The following is a description of a gene set: Regulatory circuits of STAT3 signaling studied in species Homo sapiens Human Gene Set: WP_REGULATORY_CIRCUITS_OF_STAT3_SIGNALING, and this is the list of marker genes: STAT3, MAPK7, IL5RA, SOCS3, DUSP2, EGFR, IL15RA, MLST8, JAK1, LIFR, IFNGR2, IL11RA, IL2RA, MAPK10, IL27RA, TYK2, IFNAR1, IL20RB, PIAS3, AGTR2, IFNAR2, IL22RA1, CSF3R, IL20RA, MAPK8 (NCBI Gene Id 5599), MAPK13, IL10RA, F2RL3, IL9R (NCBI Gene Id 3581), CSF2RA, PDGFRA, RICTOR, STMN1, GHR, DEPTOR, CSF2RB, IL2RB (NCBI Gene Id 3602), IL21R, MTOR, AKT1S1, RPTOR, MAPK14, MPL (MPL proto-oncogene, thrombopoietin receptor), MAPK1, IL7R, JAK3 (NCBI Gene Id 3718), PTPRT, CREBBP (CREB binding protein), CTF1 (cardiotrophin 1), MAPK3, MAPK6, IL12RB2, IFNGR1, IL10RB, MAPKAP1, IL2RG, AGTR1, PDGFRB, TRIM28, F2R, MAPK11, IFNLR1, PTPRC, MAPK9, SETD7, MAPK12, IL6R, MAPK4, IL6ST, SRC, PRKCB, MAPK15, JAK2, OSMR, IL3RA, F2RL2, PTPRD, CNTFR